Given this list of marker genes USF1, SRF, MLXIPL, KAT2B, USF2, OGT, here is a description of the gene set: species: Homo sapiens Human Gene Set: GOBP_POSITIVE_REGULATION_OF_TRANSCRIPTION_BY_GLUCOSE Any process involving glucose that activates or increases the rate of transcription.